Given this list of marker genes Ercc1, Gpx1 (glutathione peroxidase 1), Ercc4, Sdf4, Xpa, Ercc2, Ercc5, Ercc3, Mfap4, Cat, here is a description of the gene set: Any process in which an organism or cell protects itself from ultraviolet radiation (UV), which may also result in resistance to repeated exposure to UV. studied in species Mus musculus Mouse Gene Set: GOBP_UV_PROTECTION